The following is a description of a gene set: Human Gene Set: GSE8621_UNSTIM_VS_LPS_PRIMED_UNSTIM_MACROPHAGE_UP studied in species Homo sapiens from publication Mages J, Dietrich H, Lang R (PMID 18086374) Among the multiple mechanisms that control the intensity and duration of macrophage activation, the development of a state of refractoriness to a second stimulation in cells treated with LPS has long been recognized. Release of inhibitory cytokines and alterations in intracellular signaling pathways may be involved in the development of LPS tolerance. Although a number of molecules have been implicated, a detailed picture of the molecular changes in LPS tolerance is still missing. We have used a genome-wide gene expression analysis approach to (i) define which fraction of LPS target genes are subject to tolerance induction and (ii) identify genes that are expressed at high levels in tolerant macrophages. Our data show that in LPS tolerant macrophages the vast majority of LPS-induced gene expression is abrogated. The extent of tolerance induction varies for individual genes, and a small subset appears to be excepted. Compared to other negative control mechanisms of macrophages, e.g. IL-10-induced deactivation, LPS-tolerance inhibits a much wider range of transcriptional targets. Some previously described negative regulators of TLR-signaling (e.g. IRAK-M) were confirmed as expressed at higher levels in LPS-tolerant macrophages. In addition, we discuss other potential players in LPS tolerance identified in this group of genes. Genes up-regulated in untreated macrophages: naïve versus tolerant., and this is the list of marker genes: CLU, PRDM5, PRICKLE1, GRIA3, GLB1L2, STAU2, KNOP1, CELSR3, MTX3, MEAK7, LONRF3, RNASE6, STX3, TBC1D17, NBDY, TMBIM1, ARL3, RTKN, MTUS1, ITIH3, STUB1, NMNAT3, TMEM273, IL21R, EXTL2, RNF150, CCDC9, RMND1, CXXC4, PER3 (NCBI Gene Id 8863), DAND5, TRIB3, EPHB4, GPATCH4, PCLO, RAI1, RHBDF1, AICDA, AARS2, CLEC1A, FPGS, UBA7, PAICS (NCBI Gene Id 647765), CDC42BPB, SLC25A1, PLEKHH1, UTP11, TCF3, LXN, NAXE, NAA35, KANSL3, CPLX2, LDHD, SIRT4, BCL10, CNPY4, DMD, ZFP2, MARCHF10, RIN2, TERT, NIPAL2, KBTBD2, DAG1, PRR15 (proline rich 15), NRSN2, CTNNBL1, ZNF428, TCF4, CXXC5, BBS2, TP53RK, SSR3, TRARG1, ZC3H7A, PDXK, JAM2, GSTM4, OSBP, PIP5K1A, CHAF1B, DIP2C, RPL3, PKD2, LRRC66, C3orf70 (chromosome 3 open reading frame 70), FGFR1, THOC3, SSTR3, ENSA, DPP4, SH3PXD2B, PCBP2 (NCBI Gene Id 5094), FGL1, PRXL2A, RTL6, PLCG1, MPHOSPH10, SMCO2, EXOC7, MAPK14, BTBD2, FUT10, CSTPP1, NUAK1, TMUB1, SLCO1A2, AJUBA, RGMB, BASP1, MRPL11, SLC8B1, STOML2, GDF11, SPEN (spen family transcriptional repressor), STAT5A, FAM114A1 (NCBI Gene Id 92689), C9orf78, AKTIP, FBXO42, EOLA1, LRP12, CC2D2A, PRKCI, CDK2, SETD6, CFAP68, PECR, TOMM40L, MRM1, EHBP1, FUT9, TMEM100, SPI1, KCNK6, TCEAL1, NTPCR, MTCL2, ECD (NCBI Gene Id 11319), CHCHD4, AOX1, EIF3B, RHOH, VAX1, MGAT4B, FADS6, RANBP1, PITHD1, LONRF1, PLRG1, CDC5L (cell division cycle 5 like), PSMB2, DLG1, PLGRKT, SMIM11, SLC6A7, METTL5, GNA15, TRH, COQ2, ABHD15, P2RX1, LTBR, ABHD6, PRPF40B, CYP26B1, DMRT3, MPPED2, HOXA2, CTRC, CDK9 (NCBI Gene Id 1025), YJU2, UCP3, GAK, FAM98B, TMBIM4, DDX3X, SEC11A, FSTL1, UCN, TMA16, SASH1, NCOR1, REC8, MPHOSPH6 (NCBI Gene Id 10200), CNOT8, N4BP2, EARS2, IMMP2L, GP9, FAM209A, SIX5, TM2D1, TMEM106C, TSN, ERCC5, NYX, HIBADH